Given this list of marker genes Zfp213, Pax6 (paired box 6), Foxc1, Stat4, Hoxa11, Six6, Rfx4 (regulatory factor X, 4 (influences HLA class II expression)), Zfp69, Zfp317, Blvra, Alx4, Zfp850, Nr1h2, Zfp941, Glis3 (NCBI Gene Id 71622), Zfp943, Alx3, Zscan4f, Foxe1, Zfp934, Npas1, Mafb, 4930522L14Rik, Eno1, Hoxa4, Zfp446, Zhx3, Zfp369, Bhlhe40, Isl1, Zfp455, Foxb1, E2f8, Sp8, Mynn, Zkscan16, Purg, Fezf2, Pou2f2, Egr2, Cdc5l, Zscan26, Zfp711, Zfp955a, Grhl1, Pax2, Gtf2b, Safb, Nr1h5, Barx2, Hnrnpu, Trps1, Mkx, Ctcf, Chd7, Zfp689, Zfp764, Ybx3, Irx2 (NCBI Gene Id 16372), Otp, Tbx1, Sall2, Zbtb8a, Tbx19, Prdm5, Hsf1, Dlx6, Zfp184, Zfp239, Pitx2, Foxd4, Hif1a, Prdm4, Zfp54, Hoxa2, Hoxa7, Zfp354a, Hoxa5, Zfp28, Foxb2, Zfp784, Zfp13, Atf6b, Zfp59, Cebpe, Fubp1, Zfp65, Nfya, Sp1, Rfxank, Pasd1, Zfp764l1, Zfp212, Tfap2a, Zfa-ps, Zfp977, Grhl2, Bhlhe23, Nfkbiz, Nr3c2, Zgpat, Creb3l2, Zscan2, Sox15, Zfp846, Nfe2l2 (NCBI Gene Id 98874), Aebp1, Hoxb7, Sox8, Zscan4d, Batf2, B020011L13Rik, Klf14, Scrt2, Zfp746, Klf7, Zfp853, Lef1, Zfp174, Bmal1 (basic helix-loop-helix ARNT like 1), Foxl1, Foxo4, Gtf2ird1, Nr3c1, Zfp354c, Duxbl1, Nkx2-9, Zfp870, Mir208b, Six2, Gata3, Nkx2-2 (NK2 homeobox 2), Zbtb33, Mef2a, Satb2, Npas3, Zbtb32, Zbtb26, Zfp707, Zfp524, Zfp937, Hsf4, Spz1, Rbmx, Foxp1, Gm12258, Zbtb7a, Scrt1, Bbx, Zfp366, Sp4, Pbx2, Zfp612, Nkx6-1, Plagl1, Rxra, Zfp37, Purb, Nr2f1, Trp53, Zfp947, Rbmxl1, Dach1, Tcf15, Pou5f2 (POU domain class 5, transcription factor 2), Zfp516, Thra, Mybl1, Zfp637, Zkscan8, Zfp558, Gm4924, Zfp991, Smad5, Rarg, Zfp617, Snai1, Dhx36, Mycs, Dlx4, Myb, Zbtb43, Zfp551, Vax1, Sox21, Zfp84, Tgif1, Sox14, Zfp983, Zfp932, Zfp280b, Ddn, Zfp352, Ikzf4, Ppard, Klf16, Barx1, Nfatc2, Nfat5, Creb3l4, Zfp750 (zinc finger protein 750), Tbp, Snai3, Hoxd13, Nfxl1, Cdc5lrt5, Olig3, Nobox, Hoxd10, Rax, Ruvbl2, Rel, Esr2, Zfp652, Hivep3, Zfp81, Wiz, Srebf1, Usp3, Klf8, Zfp472, Zfp74, Rbpj, Hmx1, Mybbp1a, Carf, Tcf4, Pbx3, Gm17655 (predicted gene, 17655), Dmrtc1b, Creb3, Zfp97, Creb1, Zfp219, Tfcp2, Zfp444, Nfyb (nuclear transcription factor-Y beta), Sox7, Tead4, Gm35315, Tcf21, Nr2e1, Irf8, Tead2, Rhox12, Hoxd8, Zfp768, Zic1, Zfp873, Irf4, Dmtf1, Hoxd1, Zfp46, Kcnip3 (Kv channel interacting protein 3, calsenilin), Nlrc5, Lrrfip1, Fosl1, Sox3, Zfp775, Myc, Zfp599, Zfp987, Irx3, Pou5f1, Atf3 (NCBI Gene Id 11910), Nkx2-4, Zfp39, Hes1, Nfe2, Ncoa3, Zfhx3, Npas2, AW146154, Pou6f2, Suv39h2, Bcl11a, Mesp1, Hdgf, Gcm1, Nr1i2, Six4, Ep300, Ikzf2, AI854703, Sox1, Zkscan17, Onecut1, Arnt2, Zfp141, Zkscan5, Cdx4, Gfi1b, Pknox1, Mzf1, Foxi1, Zfp973, Pou2f3, Zbtb37, Hnf4a, Zfp989, Zkscan2, Etv1, Irf9, Foxe3, Helt, Zfp120, Zfp664, Ebf1, Nkx2-6, Elf1, Zfp819 (zinc finger protein 819), Ebf2, Zfp1004, Zfp704, Rxrb, Zfp985, Sim2, Gm32687, Spi1 (NCBI Gene Id 20375), Dmrta1, Neurog3, Hoxb8, Zscan4e, Nfia, Zfp954, Msx2, Tbx10, Zfp442, Sp7, Irf6, Smad9, Hbp1, Zfp367, Zfp72, Atf6, Hoxb9, Dlx2, Zfp719, Zfp286, Zkscan14, Klf12, Zfp879, Hoxc8, Fos, Ferd3l, Dmrtb1, Six1, Nhlh2, Rorc, Zbtb1, Zfp263, Zfp871, E4f1, Chd2, Zfp975, Pou4f1, Muc1, Lhx3, Hoxb3 (homeobox B3), Zfp41, Zfp341, Klf3, Hesx1, App, Zfp523, Ubp1, Hnf1a, Hoxc4, Zfp946, Zfp933, Jund, Atf4, Nfatc4, Foxa1 (forkhead box A1), Stox1, Pgr, Bcl11b, Nfkb1, Atf5, Hoxb6, Klf10, Gm14391, Nhlh1, Phox2b, Lmx1a, Zfp935, Gmeb2, Klf1, Rbpjl, Zfp607b, Prrx1, Zfhx4, Zfp68, Prox1, Dmbx1, Zfp180, Dbp, Yap1, Vdr, Kdm6b, Cdk9, Tardbp, Gm14434, Ets1, Dlx5, Hoxa6 (homeobox A6), Zbtb9, Obox5, Satb1, Mtf1, Dlx1, Bach1, Drgx, Zfp169, Hnf1b (HNF1 homeobox B), Meis1, Zfp697, Tcf7, Zfp668, Gm2381, Zfp820, Hivep1, Mitf, Meox2, Tet3, Gm614, Hlf (hepatic leukemia factor), Nkx1-2, Rhox10, Cc2d1a, Neurod6, Rfx5, Zc3h8, Clock, Osr2, Zfp408, Mxd4, Hmx2, Hmga2, Zfp266, Jdp2 (NCBI Gene Id 81703), Creb5, Irx1, Rbl1, Zfp868, Maf, Zbtb41, Snapc3, Npas4, Kdm1a, Eno1b, Zfp148, Sox2, Ebf4, Zic3, Mta1, Irf3, Dmrt1, Ebf3, Barhl2, Mef2c, Klf4 (Kruppel-like transcription factor 4 (gut)), Mlx, Zfp563, Foxf2, Mnt, Crebrf, Smad1, Nr2c2, Zfp639, Emx1, Zfhx2, Zfp990, Hes5, Zkscan3, Wbp2, Etv2, Skor1, Twist1, Zfp449, Zfp667, Zfp87, Smad3, Pou3f2, Pou1f1, Figla, Zfp866 (zinc finger protein 866), Nr1h3, Zfp110, Obox6, Msgn1, Zfp382, E2f3 (NCBI Gene Id 13557), Zfp955b, Cc2d1b, Foxo1, Tbx18, Zfp119b, Neurod4, Tbx20, Nanog, Zfp712, Tbx15 (NCBI Gene Id 21384), Hoxc5, Mixl1, Zim1 (zinc finger, imprinted 1), Tbpl1 (TATA box binding protein-like 1), Zfp329, Med12 (NCBI Gene Id 59024), E2f7, Maz, Tcf24, Zfp410, Gfi1, Rhox11, Patz1, Klf11, Zfp825, Hes2, H2az1, Pknox2, Lyl1, Dmrtc2, Mafa, Vax2, Foxf1, Prdm2 (NCBI Gene Id 74588), Zfp597, Bhlha9, Zfp821, Tfdp2, Pdx1, Gli1, Irf7, Rbak, Zbed4 (zinc finger, BED type containing 4), Zfp747l1 (NCBI Gene Id 78921), Zfp386, Maff, Ovol3, Rb1, Foxl2, Zfp30, Meox1, Zfp958, Prdm16, Erg, Hinfp, Pou3f4, Zfp105, Six3, Irf1, Nr2f2, A430033K04Rik, Plag1, Nkx3-2, Zfp874b, Foxd2, Sub1, Zbtb39, Hoxa10, Zfp358, Gm19965, Nr2e3, Obox3, Zfp113, Bsx, Mycl, Rslcan18, Bcl6, Nr1d2, Esx1, Zfp217, Tal1, Zfp85, Zbtb5, Tfap4, Spib, Pax9, Duxf3, Atoh1, Zeb1, Hoxa13, Zfp979, Zfp398, Ago1, Zbtb17, Stat2, Tbx4, Zfp507, Gata4, Cdc5lrt9, Zfp384, Dmrt3, Gm4767, Nfatc1, Ezh2, Zfp131, Tfec, Hoxc10, Ahr, Gm14325, Arnt, Fli1, Hoxb5, Pou3f3, 5730507C01Rik, Zfp7, Zfp647, Epas1, Vezf1, Zfp280d, Ar, Obox1, Zfp1006, Nr4a2, Ascl3, Cdc5lrt7, Med1 (mediator complex subunit 1), Msx1, Nsd1, 2010315B03Rik, Stat1 (NCBI Gene Id 98183), Zfp345 (NCBI Gene Id 545471), Zfp960, AI987944, Hoxa1, Zscan4b, Gm10033, Peg3, Sp2, Tbx6 (T-box 6), Irx6, Meis2, Mga, Lhx5, Tcf23, Hoxb1, Klf17 (NCBI Gene Id 98794), Zfp715, Zbtb14, Zscan4-ps3, Irf5, Max, Hoxd11 (NCBI Gene Id 319663), Zfp952, Snapc4, Hif3a, Egr3, Zkscan1, Tfap2c, Mybl2, Zscan21, Etv4, Dlx3, Rreb1, Thap11, Zfp872, Rps3, Zfp729b, Zfp971, Nr4a1, Nkx6-3, Atf7, Hes6, Nfe2l3, Foxj3, Hoxb4, Zbtb49, Prox2, Rarb, Tfap2b, Sohlh1, Zbtb10, E2f4, Zfp12, Lhx1, Tbx5, Sox13, Snai2, Stox2, Gm45871, Zfp950, Xbp1, Hoxa9, Kat2b, Platr25, Yy2, Creb3l1, Ets2, Pou3f1, Gm14443, Cphx1 (cytoplasmic polyadenylated homeobox 1), Actn4, Zfp980, Tbx22, Zfp758, Foxk1, Nkx1-1, Hoxd4, Trp73, Mafk, Relb, Rfx8 (regulatory factor X 8), Smad4, Insm2, Pou4f2, Calcoco1, Obox7, Tbx3, Spic, Zscan22, Zscan4-ps2, Foxm1, Dmrtc1c1, Neurod1, Rhox13, Bcl6b, Prdm15, Casz1, Zfp648 (zinc finger protein 648), Prdm1 (PR domain containing 1, with ZNF domain), Zfp536, Nrl, Junb (NCBI Gene Id 16477), Eomes, Dhx9, Rex2, Zfp709, Msx3, Tef, Zfp566, Neurog1, Zfp454, Zfp3, Zfp426, Gm14403, Skor2, Ppara, Zeb2, Egr4, Ski (NCBI Gene Id 99956), Ncoa2, Zfp78, Elk1, Zfp354b, Zfp663, Nr1h4, Gzf1, Zfp2, Zfp281, Zfp944, Zfp626, Msc, Nkx2-5, Glis1, Gabpa, Zfp931, Nfic, Zscan29 (NCBI Gene Id 99334), Nfib, Usf3, Med8, Zfp182, Pax1, Bmyc, Onecut3, Zfp14, Zfp984, Lhx8, Pou6f1 (NCBI Gene Id 97968), Zfp202, Pura, Mef2d, Creb3l3, Isx, Atxn3, Ciart, Mxd3, Zfp1010, Usf1, Myod1, Elk3, Zfp777, Arx, Foxa3, Zfp708, Yy1, Cdc5lrt1, Rfx6, Phox2a, Ikzf3, Mef2b, Zbtb45, Lhx2, Zfp773, Thap1, Nfix, Zfp82, Fosl2 (NCBI Gene Id 14284), 2810021J22Rik, Zfp994, Nacc1, Hoxd9, Cebpd, Atoh7, Atf1, Sox4, Foxj2 (NCBI Gene Id 60611), Zfp869, Etv6, Sox11, Klf2, Sp5, Zfp42, Zfp175, Rest, Gm14418, Zscan4-ps1, Foxp4, Hand1 (heart and neural crest derivatives expressed 1), T, Zfp383, Gli3, Mecom, Nr1i3, Prop1, Zfp324, H3f3b, Nrf1, Hoxb13, Klf15, Nkrf, Cdc5lrt6, Pax4, Zbtb11, Pax7, Zfp251, Ascl5, Ctcfl, Kdm2b, Ptf1a, Lhx9, Zfp964, Macroh2a1, Zfp58, Sp6, Zfp160, Zscan25, Alx1 (NCBI Gene Id 216285), Gata2, Tcfl5, Gm7072, Mxd1, Macroh2a2, Pax5, Ddit3, Zkscan4, Zfp568, Prdm14, Zfp970, Zfp580, Pou2f1, Cux1, Dnmt3a, Sp3, Atf1-ps, Smyd3, Hdac1, Zfp692, E2f5, Hmga1, Rela, Klf13, Lhx4, Zbtb16, Esrra, Foxd3, Zfp248 (NCBI Gene Id 78001), Zfp616, Zfp811, Zfp459, Hoxc9, Sox6, Zbtb20, Rad23b, E2f2, Zfp335, Tcf12, E2f1 (E2F transcription factor 1), Nkx2-3, Ovol2, Nkx2-1, Zfp747, Zfp101, Zfp90, Cux2, Gcm2, Srf, AU041133, Hdx, Etv5, Pitx3, Glis2, Zfp395, Zfp119a, Zbtb34, Zkscan6, Heyl, Tcf3, Zfp534, Klf5, Tfcp2l1, Bach2, Sox18, Nrip1, Foxa2, Zfp763, Sox5 (SRY (sex determining region Y)-box 5), Hoxc13, Dmrt2, Nacc2, Skil, Ccar1, Nr4a3, Zfp961, Rfx2, Preb, Zfp691, Hoxc11, Zfp1, Bhlhe41, En2 (engrailed 2), Zfp189, Zfp799, Mlxip, Hes3, Mxi1, Zfp930, Nfe2l1, Mtf2, Zfp628, Esrrg, Ikzf1, Gsc2, Foxj1, Zfp790, Gm3604, Zfp951, Cry1, Sry, Ascl1, Thrb, Rara, Gata5, Zfp420, Zfp157, Ncor1, Runx1, Lhx6, Runx2, Gli2, Eef1d, Tbx2, Nr6a1, Elf4, Nme1, Myf6, Elf3, Wt1, Zfp143, Zfp607a, Aire, Gata1, Duxf4 (NCBI Gene Id 245263), Zfp956, Nfkb2, Cdx2, Foxp2, Bptf, Rfx3, Dmrtc1a, Elk4 (ELK4, member of ETS oncogene family), E2f6, Top1, Zfp322a, Bcor, Myt1l, Zfp623, Zfp513, Zbtb7c, Zbtb7b, Tbr1, Nr5a2, Hey2, Zbtb25, Cebpb, Prdm11, En1, Esrrb, Lmx1b, Irx5, Jun, Mafg, Zfp146, Insm1, Rfx1 (regulatory factor X, 1 (influences HLA class II expression)), Zfp988, Batf, Sohlh2, Zscan4c, Fev, Irx4, Hmx3, Cdc5lrt4, Gm14401, Olig1, Hoxa3, Klf9, Zfp772, Stat5b, Neurod2, Zfp740 (zinc finger protein 740), Mycn (NCBI Gene Id 18109), Trim24, Foxk2, Crebbp, Evx2, Zfp493, Trp63, Zbtb22, Ehmt2, Bhlha15, Foxs1, Sirt1, Zfp992, Hoxc6, Zfp277, Cdx1, Zfp280c, Zfp672, Sp140, Stk16, Per2, Dmtf1l, Bmal2, Foxo6, Rbbp4, Elf5, Ogg1, Hdac5, Tfe3, Suv39h1, Cdc5lrt8, Pax8, Gbx1, Gm14444 (NCBI Gene Id 105244402), Zfp981, Suz12, H3f3a, Rsl1, Hivep2, Zfp655, Cdc5lrt10, Nkx6-2, Sox17, Stat3, Zfp644, Zfp683, Barhl1, Tfeb, Tal2, Tet1, Kcnh8, Zscan10, Mypop, Zfp575, Zfp867, Dach2, Zfp963, Sp9, Atoh8, Hand2, Zfp998, Pou4f3, Runx3, Zfp128, Zfp456, Smarca4, Gmeb1, Tead3, Rbl2, Gm14322, Tfdp1, Nfx1 (NCBI Gene Id 93788), Gtf2a1, Sox30, Zfp92, Evx1, Zic4, Obox2, Zbtb12 (NCBI Gene Id 279934), 2610008E11Rik, Sars1, Zic2, Gm6871, Ehf, Zfp641, Onecut2, Tfap2e, Zfp260, Crx, Adnp, Foxq1, Cic, Zfp976, Hdac2, Zfp982, Rfx7, Pax3, Zfp273, Zfp24, Zfp809, Zic5, Egr1, Zfp966, Sox10, Osr1, Zbtb24, Zfat, Taf1, Nr2f6, Hhex, Zfp940, Zfp433, Hsf2, Hdac4, Hey1, Hnf4g, Zfp9, Emx2, Cebpg, Zfp560, Six5, Tead1 (NCBI Gene Id 70301), Nfyc, Dmrta2, Pparg, Otx2, Obox8, Zfp874a, Grhl3, Mesp2, Cebpa, Zfp53, Gbx2, Sox9, Prrx2, Ascl2, Rora, Zfp995, Per1, Uty, Esr1, Myf5, Zfp429, Hoxb2, Zfp949, Ikzf5, Vsx2, Zfp1007, Zbtb4, Rorb, Zfp512b, Ovol1, Zfp275, Myef2, Gsx1, Neurog2, Gm5141, Nr1d1, Zfp696, Zfp710, Tcf7l1 (transcription factor 7 like 1 (T cell specific, HMG box)), Zscan12, Batf3, Ncoa1, Irf2, Srebf2, Myog, Foxo3, Foxi2, Nr5a1, Foxl3, Noto, Mlxipl, Foxp3, Hcfc1, Zfp583, Zscan20, Pitx1, Gm14399, Sox12, Zfp942, Zfp582, Zbtb6, Tcf7l2, Zfp334, Etv3, Myt1, Zfx, Gsc, Thrap3, Olig2, Twist2, Nfil3, Usf2, Foxc2, Zfp287, Rfxap, Litaf (LPS-induced TN factor), Zbtb38, Zfp236, Stat5a, Rxrg, Gm15446, Crem, Nkx3-1, Zfp882, Otx1, Ascl4, Zbtb2, Zfp397, Gata6, Zfp865, Zfp362, Scx, Stat6, Foxd1, Zfp296, Pbx1, Kdm6a, Hes7, Prmt5, Atf2, Hdac6, Zfp418, Zscan5b, Smad2, Fezf1, Zik1, BC024063, Bhlhe22, Tfap2d, Fosb, Nfatc3, Sim1, Tbx21, Nr2c1, Zkscan7, Klf6, Zfp810, St18, Deaf1, Zfp677, Hoxd3, here is a description of the gene set: species: Mus musculus Mouse Gene Set: GOMF_RNA_POLYMERASE_II_TRANSCRIPTION_REGULATORY_REGION_SEQUENCE_SPECIFIC_DNA_BINDING Binding to a specific sequence of DNA that is part of a regulatory region that controls the transcription of a gene or cistron by RNA polymerase II.